Given this list of marker genes TMEM120B, TGFB1I1, BBS1, FTO, HMGA2, SDF4, SLC39A13, TRIB2, SIX1, MIR27B, HDAC6, PRLH, ZNF385A, ADRB3, SAV1, CCDC3, GNB3, MEX3C, FOXO1, FFAR2, PPARD, ALOX5, BMP7, PTGR3, ID4, FAM83A, BBS9 (Bardet-Biedl syndrome 9), OSBPL11, PLAC8, SFRP1, ADGRF5, LMO3, AXIN1, TMEM64, GDF3, TTC8, EP300, SFRP2, CCDC85B, HNRNPU, ZFP36L2, ALOXE3, WNT3A, GATA2, SREBF1, TRIB3, ERO1A, TGFB1, ADRB2, CMKLR1, TPH1, ALDH6A1, FNDC5, WNT5B, NR1D1, PNPLA3, AKT1, XBP1, ZFPM2, FGF10, WNT10B, NIPBL, DUSP10, IFRD2, NEGR1, IL6, PID1, SULT1E1, IL11 (NCBI Gene Id 3589), RARRES2, ARID5B, RGS2, EGR2, CTBP1, ZBTB7C, MB, LRRC8C, FITM1, UCP1 (uncoupling protein 1), MIR106A, ERAP1, METRNL, CCND1, GPR180, NUDT7, BBS2, SIRT2, GRK5, RNASEL, PTPRQ, ADIG, EBF2, BMAL1, CEBPA, PIM1, PTGS2, BMP2, LEP, CREB1, CARM1 (NCBI Gene Id 10498), PRDM16, YAP1, MIR17, STEAP4, MAFB, ARL4A, MSX2, RETREG1, ATF5, TRPV4, MIR29B1, ATF2, ENPP1, ANKRD26, MIR103A1, SLC7A10, MIR181A2, RUNX1T1, PLCB1, TFAP2B, SIRT6, SYAP1, WDFY2, HTR2A, SENP2, ANGPTL8, ASXL2, TBL1XR1, SH2B2, TCF7L2, FABP4, PSMB8, RREB1 (ras responsive element binding protein 1), PER2, MIR483, DKKL1, CTBP2, ZC3H12A (zinc finger CCCH-type containing 12A), SOX8, MED1, NR4A1, GPER1, GPS2, RORC, GPX1, BBS12, DLK2, LRG1, BNIP3, BBS4, SOX13, TFE3, KLF4, NAPEPLD, PDGFRA, LPL, CNTN2, IFRD1, AAMDC, ARL6, FFAR4, NR4A2, KCNJ8, ADIRF, OSBPL8, ZBTB16, SMAD6, ZBTB7B, NOCT, TLCD3B, PPARGC1A, MIR138-1, FAM120B, MMP11, RETN (resistin), ASXL1, SMAD3, MIR107, VEGFA, SIRT1, OPA3, DDIT3, FBXO9, SORT1, NR4A3, WWTR1, FERMT2, MIR21, ADRB1, SOD2, CEBPB, LAMB3, BSCL2, MAPK14, FLCN, BCL2L13, HES1 (hes family bHLH transcription factor 1), ADIPOQ, CIDEA (cell death inducing DFFA like effector a), ATAT1, WIF1, PIAS1, MIR448 (microRNA 448), TNF, FITM2, STK4, CREBL2, TMEM120A, MKKS, JAG1, FRZB, STK3, FOSL2, JDP2, ID2, MIR128-1, LRP3 (NCBI Gene Id 4037), TRPM4, ZFP36, INHBB, FABP3, LRP5, CDS1, MEDAG, MIR548D1, SOCS1, GDF6, ZBTB7A, C1QL4, MIR27A, ADGRF1, AKT2, INS, CLIP3, TRIO, BBS7, PEX11A, TAF8, HTR2C, SLC2A4, NOC3L, AXIN2, CCN4, GDF10 (growth differentiation factor 10), PPARG, CBY1, CEBPD, C1QTNF3, ZFP36L1, SNAI2, INSIG1, WNT1, RORA, WNT5A, KLF5, VSTM2A, NPR2, ZNF516, E2F1, TRIM32, here is a description of the gene set: Human Gene Set: GOBP_FAT_CELL_DIFFERENTIATION species: Homo sapiens The process in which a relatively unspecialized cell acquires specialized features of an adipocyte, an animal connective tissue cell specialized for the synthesis and storage of fat.